The following is a description of a gene set: Reactome Pathway: Interleukin-27 signaling species: Mus musculus This event has been computationally inferred from an event that has been demonstrated in another species.<p>The inference is based on the homology mapping from PANTHER. Briefly, reactions for which all involved PhysicalEntities (in input, output and catalyst) have a mapped orthologue/paralogue (for complexes at least 75% of components must have a mapping) are inferred to the other species. electronically inferred by orthology from the curated human pathway part of: Interleukin-12 family signaling, and this is the list of marker genes: Ebi3, Il27ra, Crlf1, Il27, Tyk2